Given this list of marker genes TRIM5, CRELD2, TDRD7, PDLIM1 (NCBI Gene Id 9124), GCKR, CDC34, CFB (NCBI Gene Id 629), TMEM62 (transmembrane protein 62), WBP4, HOXA10, ADGRE1, SHFL, RFPL2, DDX60, BST2, ISG20, IFI35, SPATS2L, NT5E, STAT1, TRIM14, GBP1, PRKD2, TRAF4, NR4A1, HLA-E, IFIT5, APOBEC3B, PRMT7, IFI27, TAPBP, PTPN7, OGFR, TRIM22, TCL1B, EXT1, CDK18, DPT (dermatopontin), PSME1, PSME2, LTBR, IL19 (interleukin 19), ISG15, LMF2, NMI, PLAAT4, SP140L, IFITM2, CMTR1, APOL1, IFI44L (NCBI Gene Id 10964), CRYAB, SMAD6, CHD7, USP18, TUBA4B, HLA-J, PLSCR1, SECTM1 (secreted and transmembrane 1), IFIT3, ZNF277, SEPTIN4, CUL9 (NCBI Gene Id 23113), HLA-C, TREX1 (NCBI Gene Id 82474), RNF31, MAB21L4, TAP2, OAS1, HERC5, HIF1AN, IFITM3, CCR8, EIF2AK2, CXCL1, OAZ3, LY6E, LGALS3BP, HLA-F, TOP3B, MMP20, IGFBP3, DYNC1LI1, IFIT1 (NCBI Gene Id 8374), PSMB8, UBE2L6, TRANK1, ATP6V1H, IFI30, ZFP36, NT5C2, PCDHA10, SLC25A10, P4HA1, TBL2, TYROBP, SERPINB8, HSPA9, MYO1E, MX1 (MX dynamin like GTPase 1), CRH (corticotropin releasing hormone), APOC2, LAP3, L2HGDH, ADAM2, GDNF, IRF9 (interferon regulatory factor 9), KRT16, ALPK3, MEF2D, PTBP1, SAMD9, FABP2, DOK3, MISP, IFI44, RAB9BP1, OR2H1, CD101, TEF, MMRN1, C1R, RNF113A, BRD1, ZNF721, RIGI, HLA-B, IFI6, HSD3B2, UNC93A, TAP1, H1-10, SERHL2, ROR2, OAS2, DUSP13B, GRAPL-AS1, PML, ADAR, CYP2J2, IFI16, SAMHD1, LMO2, OASL, DSC2, TRIM38, IRF7, B2M (beta-2-microglobulin), KCNIP2, PHF11, APBB1IP, SPANXC, IFIH1, ADRA1B, HLA-G, P2RY11 (purinergic receptor P2Y11), LAMP3, UNC93B1, CHCHD7, RGS2 (NCBI Gene Id 5997), KLHL29, FZD10 (NCBI Gene Id 11211), PSMB9, SLC9A8, OAS3, HERC6, DDX24, SP110, ZNF768, IL1RN, TYMP, MYD88, C1S, B3GALT5, PARP12, PRDM4, PGS1, RFC2, ZNF426, PDIA3, C3, IFITM1, HLA-A, CD38, TLL1 (NCBI Gene Id 7092), NECTIN2, PLAGL2, TRIM21, MX2, SLC38A4, TFG, CRYZL1, HCP5, ZSCAN9, SP100, DROSHA, NOC4L, SLC19A1, here is a description of the gene set: We investigated at which stage of maturation commitment to a stable Foxp3-expressing phenotype takes place. We assessed stability of Foxp3 expression in thymic Foxp3+ Treg subsets of different maturity, defined by CD24 expression. Next we compared gene expression profiles of Foxp3+ Treg subsets (+) of different maturity (24lo, 24int, 24hi) and could identify a set of genes that were specifically up or downregulated in Foxp3+ Tregs, but not in Foxp3- conventional T cells, in a maturation-dependent manner. studied in species Homo sapiens Human Gene Set: GSE42021_TREG_PLN_VS_CD24LO_TREG_THYMUS_DN from publication Toker A, Engelbert D, Garg G, Polansky JK, Floess S, Miyao T, Baron U, Düber S, Geffers R, Giehr P, Schallenberg S, Kretschmer K, Olek S, Walter J, Weiss S, Hori S, Hamann A, Huehn J (PMID 23420886) Genes down-regulated in T reg: peripheral lymph nodes versus thymic CD24 low.